Given this list of marker genes LIPE, LMNA, POMC, MT-TK, KLHL41, TCAP, GATA1, MC4R, POLR3A, PLEC, INPP5K, ANO5, PCSK1, RYR1, LAMA2, KLHL40, ACTA1, DYSF, AIFM1, NEB, LMOD3, LIMS2, UROS, AKT2, PIK3CA, CHCHD10, NEFL, TNXB, here is a description of the gene set: species: Homo sapiens The presence of an abnormally increased amount of connective tissue. Increased connective tissue Human Gene Set: HP_INCREASED_CONNECTIVE_TISSUE